Given this list of marker genes RPL15, RPS28, NKX2-1, B3GLCT, NRAS (NRAS proto-oncogene, GTPase), PPP1CB, ZMPSTE24, FILIP1, RPL11, XYLT2, TNNI2, GPC3, BLTP1, NALCN, SEMA3E, MEGF8, KAT6A, IGF1R, RRAS2, LMNA, BRAF (B-Raf proto-oncogene, serine/threonine kinase), MEOX1, RYR1, RPS26, RPL18 (NCBI Gene Id 6141), LAMA5, TPM2, RPS7 (ribosomal protein S7), RPS24, MAP3K7, RPL26, ANKRD11, LZTR1, CHD7, RAF1, DVL3, SALL4, SHOC2, PIK3CA, RPL9, SPRED2, MKS1, PIGL (NCBI Gene Id 9487), GDF6, RPL27, CHN1, RPS27, FGFRL1, KMT2A, BMPER, RIT1, FOXC2, RPL35, ERI1, AMER1, EFNB1, SMS, RPS29, RRAS, BCOR, MAFB, NAA10, RPL5, FANCL, GATA1, RPS20, TNNT3, GPC4, RB1, LETM1, SLC35A1, AEBP1 (AE binding protein 1), CHRNG, TBX2, ACTB, HEATR3, CPLX1, RPL31, SOS2, ALDH1A2, C2CD3, MYH3, MRAS, GLE1, SNRPB, FBXW11, RASA2, WBP11, LMX1B, SRY, CHST3, SLC39A13, TSR2, FLI1, GATA2, TMEM94, TMEM260, PIEZO1, RPS15A, RPS10 (ribosomal protein S10), MAP2K1, RPS17, MYO18B, MAP2K2, NSD2, CBL, B3GAT3, CDC42, TAPT1, HRAS, KRAS, GDF3, RPL8, MAPK1 (mitogen-activated protein kinase 1), ADA2, RPS19, STXBP1, ACTG1, TASP1, RPL35A, NF1 (neurofibromin 1), CTBP1, SOS1, PTPN11, here is a description of the gene set: species: Homo sapiens Pterygium colli is a congenital skin fold that runs along the sides of the neck down to the shoulders. It involves an ectopic fibrotic facial band superficial to the trapezius muscle. Excess hair-bearing skin is also present and extends down the cervical region well beyond the normal hairline. Human Gene Set: HP_WEBBED_NECK Webbed neck